The following is a description of a gene set: species: Homo sapiens Refractory anemia with ringed sideroblasts A type of myelodysplastic syndrome characterized by less than 5% myeloblasts in the bone marrow, but with 15% or greater red cell precursors in the marrow being abnormal iron-stuffed cells called ringed sideroblasts. Human Gene Set: HP_REFRACTORY_ANEMIA_WITH_RINGED_SIDEROBLASTS, and this is the list of marker genes: TET2, ERBB3, SF3B1, HSCB, HSPA9 (NCBI Gene Id 91471)